The following is a description of a gene set: Human Gene Set: GOBP_VIRAL_RNA_GENOME_REPLICATION The replication of a viral RNA genome. studied in species Homo sapiens, and this is the list of marker genes: APOBEC3H, ATG16L1, AICDA, TOP2B, APOBEC3G, FBXL2, PCBP2, APOBEC3B, HMGA2, APOBEC3D, FMR1, TRIM28, SMARCB1, CXCL8, ATG16L2, PHB1, APOBEC3F, DDX56, ATG5, PCBP1, TMEM41B, INPP5K, APOBEC3C (NCBI Gene Id 91578), APOBEC3A, VAPB, TOP2A